The following is a description of a gene set: Human Gene Set: MIR1226_3P species: Homo sapiens Genes predicted to be targets of miRBase v22 microRNA hsa-miR-1226-3p in miRDB v6.0 with MirTarget v4 prediction scores > 80 (high confidence targets). from publication Chen Y, Wang X (PMID 31504780), and this is the list of marker genes: ELAVL3, FAHD1, NFIA, CRTAP, LETM2, PPP6R1, ZNF224, HCN1, HIPK1, VAMP3, DVL3, ATF2 (NCBI Gene Id 1386), KCNMA1, ERICH4, TPRX1, CCDC71L, FAM53C, HGD, SZRD1, RPS6KB1, CD55, STX17 (syntaxin 17), WDR5, GRIK5, ZBTB40, FURIN, MTREX, RMDN3, FGF2, APPL1, ADNP, TMEM222, HRK, CREBBP, NUP153, HOXD3, RCAN2, TFEC, ATP2A2, PPP6R2, GSDME, GPR65, ERVFRD-1, PI15, ANXA11, ADRB1, ITSN1, AAMP, APIP, PRRX1, ZNF83, NAT8L, EIF2A, ZNF436, MAT2A, VASH1, AIG1, ST8SIA1, XRCC2, ZNF512B, INSR, EEIG1 (NCBI Gene Id 90676), FAAP100, CAST, ABCG1, ZNF500 (zinc finger protein 500), ABCA12, ZMYM2, ZDHHC5, COPG1, SHISAL1, AKR1C1, AKR1C2, PLCXD3, SEPTIN3, FBXW7, ADGRL3, NAA50, IGF2R, PTPMT1, LRTM2, VPS53, COL12A1, TMEM255A, CNNM4, THAP11, PPFIBP1, TVP23A, SEMA5A, DLG2, AR, SPON1, TTC9B, RRP1B, YBX3, RIMKLB, ZNF189, CD180, CHD3, ANKRD40, OGT, DCLK3, CHST11, GAS7, MORC2, FAM168B, UACA, AKR1C4, TIMM9, FBXO11